Given this list of marker genes OSTM1, STRAP (serine/threonine kinase receptor associated protein), ZWINT, PCF11, FBLN1 (NCBI Gene Id 2192), AMACR, EPG5, RUNX1T1, FAXC, LEPR, RAB1B, ZNF830 (zinc finger protein 830), SCYL2, CYP4F2, PANK1, FZD3, SLC1A3, PBRM1, CYP4F3, PLOD2, GFRA2, CNEP1R1, NCOA2, SETD9, ELOA, TMEM67 (transmembrane protein 67), ANKRD33B, BEX3, STRIP2, CBR1, CHMP4B, ZNHIT3, SYNDIG1, ATRN, EFNB2, WTAP, DMD, PRRC2C, ITGA9, NCMAP, SEPTIN4, NAALADL2, STXBP1, OSBPL9, LRP1B, MYDGF, CCSER1, CLMN, EIF3D, ASPH, TTLL3, CEP57, ZFHX3, CHN1, C5orf24, SRSF1, SSB, GALK2, MME, PPP2R2D, PCDH12, FKTN, MXI1 (MAX interactor 1, dimerization protein), BTLA, SIPA1L2, KIF13A, FMN1, ARID2 (NCBI Gene Id 57676), KCNG3, AKIRIN2, RAB5IF, KCNH7, MAT2B, SP4, GRHL1, SALL3 (NCBI Gene Id 27164), SLC38A2, SASH3, FHIP1B, ATF7IP, AKAP5, TNF, NRG1 (NCBI Gene Id 653104), SERPINB8, SLC30A4, LIFR, TRIO, PELI1, GVQW3, ERLIN2, GJA3 (NCBI Gene Id 2700), SEZ6L, RGS21, CDK6, TBK1, DDHD1, TBC1D28, PAK1, SUGCT, BAG4, PPFIA1, SULF1, FBXO39, OPRL1, NLGN1, SOCS6, ARL15, ZMIZ1, ATE1, ANKS6, ZNF704, CCSER2, TGIF2-RAB5IF, NT5E, SLC66A1LP, ATP6V1G3, TCEANC2, TMEM106B, UBASH3B, CBLL1, AMER1, GPR34, PFN2, PRLR, TMEM263, ABCA5, LRP2, BIK, SELENOK, ANKDD1B, DNAJC6, here is a description of the gene set: from publication Chen Y, Wang X (PMID 31504780) Human Gene Set: MIR452_3P Genes predicted to be targets of miRBase v22 microRNA hsa-miR-452-3p in miRDB v6.0 with MirTarget v4 prediction scores > 80 (high confidence targets). species: Homo sapiens